The following is a description of a gene set: Human Gene Set: GOBP_REGULATION_OF_RESPIRATORY_GASEOUS_EXCHANGE_BY_NERVOUS_SYSTEM_PROCESS A process carried out by the nervous system that is required for the proper control of respiratory gaseous exchange. This process occurs in the respiratory center of the brain in vertebrates. species: Homo sapiens, and this is the list of marker genes: TLX3, GLS, GLRA1, NLGN2, ADORA1, PHOX2B (NCBI Gene Id 8929, paired like homeobox 2B), TSHZ3, CC2D1A, GSX2, PBX3, NLGN3, MECP2, ATP1A2